Given this list of marker genes OXTR (oxytocin receptor), OXT, AVPR1A, AVP, AVPR2, AVPR1B, here is a description of the gene set: part of: Peptide ligand-binding receptors studied in species Homo sapiens Reactome Pathway: Vasopressin-like receptors The vasopressins are peptide hormones consisting of nine amino acids (nonapeptides). They include arginine vasopressin (AVP; anti-diuretic hormone, ADH) and oxytocin. They are synthesized in the hypothalamus from a precursor and released from stores in the posterior pituitary into the blood stream. One of the most important roles of vasopressins is the regulation of water retention in the body. Oxytocin is important in uterine contraction during birth. The vasopressins act via AVP and oxytocin receptors. These are connected to G proteins which act as second messengers and convey the signal inside the cell.